Given this list of marker genes Lynx1, Ric3, Ly6g, Ly6e, Ly6i, Ly6c2, Ly6g6e, Ubxn2a, Rapsn, Ly6g2, Psca, Ly6h, Ly6c1, Slurp2, App, Ly6a (NCBI Gene Id 17065), Ly6g6g (NCBI Gene Id 78725), Ly6f (lymphocyte antigen 6 family member F), Ly6m, Nrxn1, Dlg4, Rer1, Lypd1, Jak2, here is a description of the gene set: Mouse Gene Set: GOMF_ACETYLCHOLINE_RECEPTOR_BINDING studied in species Mus musculus Binding to an acetylcholine receptor.